The following is a description of a gene set: A lesser degree of hair pigmentation than would otherwise be expected. Human Gene Set: HP_FAIR_HAIR species: Homo sapiens Fair hair, and this is the list of marker genes: SLC17A5, SLC24A5, TAFAZZIN, BLOC1S5, SNRPN, UBE3A, PDE4D, IFT140, LPAR6, TP63, ZFX, KANSL1, RMRP, DPP9, PAH, ABCA2 (NCBI Gene Id 23153), AP3B1, UBR1, MOGS, PIGN